Given this list of marker genes Camsap3, Tjp1, Mtss1, Kifc3, Pkp2, Plekha7, Fermt2, Afdn, Inava, here is a description of the gene set: species: Mus musculus The maintenance of an adherens junction. An adherens junction is a cell-cell junction composed of the epithelial cadherin-catenin complex at which the cytoplasmic face of the plasma membrane is attached to actin filaments. Mouse Gene Set: GOBP_ADHERENS_JUNCTION_MAINTENANCE